Given this list of marker genes WASHC3, DOP1B, AKT2, VIPAS39, OSBPL6, DTX3L, RUBCN, ALS2, SNX3, LDLRAD4, NISCH, CRYZL1, IFITM3, INPP5F, ITCH, CLVS2, AOC3, PTP4A3, MICALL1 (MICAL like 1), CD8B, RHOB, RAPGEF1, TMEM108, FZD5, NSG2, SGK3, TLR9, TOLLIP, HAP1, LTF, APOA5, HSPD1, RAB5B, UVRAG, ARL8B, SLC11A2, WASHC2A, TBC1D16, DKK1, TPCN1, NME1, ACKR3, HLA-C, OR51E2, CAV1, ZFYVE9, VPS33B, PARM1, GPR65, WDFY2, SORT1, VPS8, RAB1A, ARF6, ATP11C, HLA-DRA, LAMP5, STAM2, SNX21, HLA-H, NIPA1, VPS4A, AP1S1, CLEC10A, PTP4A2, STAM, STX12, NSG1 (NCBI Gene Id 27065), SLC30A10, SYNDIG1, EPS15, SH3GL2, WDR81, NIPA2, APOA1, HAS3, ATP13A4, ENTREP1, EPHB1, MON2, HPS6, FERRY3, TMEM63A, WNT3A, MYO1D, WASHC5, STX8, F8A1, RAP1A, WASHC1, SORCS2, ATP11B, MAP2K2, APOE, HFE, FLOT1, CLN3, NCSTN, ARC, CMTM6, TMEM63B, AP3M2, RAB20, WIPF3, ASAH1 (N-acylsphingosine amidohydrolase 1), SNX1, CXCR4, KIF16B, SNX20, NTRK2, USP10, SIGLEC1 (NCBI Gene Id 6614), ANXA1, LMTK2, FGD5, ANKRD27, TMEM163, ABCB9, VAMP3, WASHC4 (NCBI Gene Id 23325), C8orf44-SGK3, SNX4, CLCN4, GRIPAP1, ECE1, PLEKHJ1, ATP6V0D1, EHD2, FCMR, AP1S2, PI4K2B, PACSIN2, VPS13B, MMGT1, PICALM, TOM1, CLN6, ADRB1, NTRK1, TBC1D3, MGRN1, PHETA1, COMMD1, ACKR2, RAB17, HTT, RAB5A, CCDC154, ZFYVE28, RCC2, KIAA0319, PLA2G4E, DYSF, ANXA2, ATP9A, MYO5A, PLA2G4B, MME, CLCN5, VPS28, CD207, PIKFYVE, SLC15A4, AP1M1, VPS35, HPS3, WASH3P, TRAK2, BACE1, GRIA1, WASHC2C, BLOC1S1, B2M, AP3D1 (adaptor related protein complex 3 subunit delta 1), LAPTM4B, SIAH2, VAC14 (NCBI Gene Id 55697), SLC5A1, ARRDC4, DNAJC13, RAB11FIP5, TMEM30A, PLD3, RAB32, MR1, RAB31, DERL1, TFRC, DBNL, CHMP3 (NCBI Gene Id 51652), EEA1, STX7, OCRL, AGER, RUFY1, MAP2K1, AP4M1, APP (NCBI Gene Id 351), ADRB2, CFTR (NCBI Gene Id 1080), VPS11, HLA-F, AP1S3, SNX12, SNX16, RAB14, HGS, REP15, RAC1, TLR3, PLPP2, VCAM1 (vascular cell adhesion molecule 1), AP3S1, GPER1, BOK, VPS18, F2RL1, KDR, NAPEPLD, SLC2A13, CD22, ACKR4, CD4, AP1B1, LAMP3, PCSK9, LLGL1, MELTF, LNPEP, EPHA4, RABEP1, EPHA3, EPHA8, HLA-E, PSEN2, AP1AR, TRAK1, FKBP15, RAB29, HSD17B6, CLTCL1, RAB5C, SNX19, APBB2, HAVCR2 (hepatitis A virus cellular receptor 2), PLEKHF2, TRIM27, LDLRAP1, ANGPTL3, ANKFY1 (ankyrin repeat and FYVE domain containing 1), DIAPH2, WDFY1, TRIM3, RAB4A, SH3GL3, SLC5A7, CCDC93, ASTN2, IGF2R, RNF11, CD1E, CNTNAP2, ECPAS, PI4K2A, WDFY4, RPS6KC1, HYAL3, RASGEF1B, TMEM127, DNER (NCBI Gene Id 92737), ATP11A, KIFC1, HPS5, UBXN6, VPS33A, MIB2, PTPN23, SNX30 (NCBI Gene Id 401548), WASF2, ZMPSTE24, STX6, GATD1, USP8, ACKR1, MLC1, SLC39A14, FCGR1BP, PLD4, TMEM9B, CLIP3, RAB21, MTMR2, CLCN3, RAP1GAP, LRP6, NOX1, SLC9A3, STAMBP, SAMD9L (NCBI Gene Id 4827), LRP1, ABCA7, AP1G1, MARCHF1, APOA2, INPP4A, HLA-G, LIPG, VAMP8, EGFR, AP3B1, APOC2, TMEM230, ABCB6, APOC3, MTMR4, AP3B2, PLEKHA3, ARAP1, TICAM2, RABEP2, VPS29, RAB38, SNX27, RFTN1, APPL2, VPS41, SNX31, ERBB2, MARCHF3, F8A3, SLC9A9, PHETA2, TLR4, MAPKAP1, TM9SF4, GGA1, WASH6P, MCOLN3, SIAH1, FCGR1A (Fc gamma receptor Ia), MYO1B, LDLR, ZFYVE26, APH1A, BLTP3B, NEURL3, LITAF, ARRDC3, ENTR1, TSG101, NEURL1B, PLEKHF1, APPL1, CORO1A, PSEN1, RCSD1, GGA3, KREMEN2, CLVS1, TGFBRAP1, ANKRD13B, ATP7A, RAB22A, SPHK1, FGD2, CACFD1, APOA4 (NCBI Gene Id 337), ANK2, F2R, PML (NCBI Gene Id 5371), TMEM184A, CACNG7, ATP13A3, RAB4B, PDLIM4, SLC31A1, EHD3, GPNMB, EHD1, RIN3, SLC35D3, AP3M1, PHB1 (prohibitin 1), HLA-A, PTP4A1, NEU3, MVB12B, VPS26A, CD274, PTPN1, SNX6, RBSN, DAGLA, KCNH1, VPS26B, CYTIP, HMGB1, TBCK, MAPK3, RUSC1, STEAP4, RABGEF1, MARCHF8, MAGEL2, TBC1D2B, SNX17, ZFYVE16, KCNQ1, MAPK1, AP3S2, VPS16, PPP1R21, SORL1, CHMP1A, DERL2, ST8SIA2, EHD4, PRDX3, SLC9A6, BAIAP3, GPR107, SNX8 (NCBI Gene Id 29886), FIG4, SH3GL1, NF2, ATP6V0D2, SNX13 (NCBI Gene Id 23161), STEAP2, NUMB (NCBI Gene Id 94910), F8A2, KIR2DL4, TF, TICAM1, VTI1B, SERPINB1, HLA-B, SNX2, APOB (NCBI Gene Id 338), GGA2, NRP1, RABGAP1L, SNX5 (sorting nexin 5), WDR91, WLS (Wnt ligand secretion mediator), CTNS, RHOD, INPP5B, C1orf210, SNX7, PMEPA1, SLC1A1, here is a description of the gene set: A membrane-bounded organelle that receives incoming material from primary endocytic vesicles that have been generated by clathrin-dependent and clathrin-independent endocytosis; vesicles fuse with the early endosome to deliver cargo for sorting into recycling or degradation pathways. Human Gene Set: GOCC_EARLY_ENDOSOME species: Homo sapiens